Given this list of marker genes Cep192, Stil, Cep295, Cenpj, Rbm14, Spice1, Trim37, Plk4, Cep120, Alms1, Mdm1, Poc1b, Cep76, Kat2b, Ccdc15 (NCBI Gene Id 245902), Cep295nl, Vps4b, Npm1, Ppp1r35, Plk2, Kat2a, Sass6, Cdk5rap2, D7Ertd443e, Nup62, here is a description of the gene set: studied in species Mus musculus Mouse Gene Set: GOBP_REGULATION_OF_CENTRIOLE_REPLICATION Any process that modulates the frequency, rate or extent of the formation of a daughter centriole of an existing centriole.